The following is a description of a gene set: Human Gene Set: GOCC_PHAGOCYTIC_VESICLE_MEMBRANE The lipid bilayer surrounding a phagocytic vesicle. species: Homo sapiens, and this is the list of marker genes: MTMR4, RAC2, HLA-F, VAMP3, RAB9A, PIK3C3, TAP2, RAB11FIP1, RILP, SEC22B, ATP6V0D1, MCOLN1, STX4, RAB38, RAB9B, SLC9A9, ATP7A, RAB11B, RAB20, TAPBP, TLR2, RAB5A, HLA-H, DMBT1, B2M, HLA-C, LAMP1, DNM2, IRGM, RAB32, CORO1A, RAB10, HLA-B, INPP5B, TCIRG1 (T cell immune regulator 1, ATPase H+ transporting V0 subunit a3), HVCN1, ATP6V0E2, ATG12, RAB22A, RAB7A, ATP6V0A1, TAP1, PIP4P1, CALR, RAB34, ATP6V0C, RAB7B, PIK3R4, RAB31, RAB23, VAMP8, SNAP23, VAMP7, CLEC4E, ATG5, RAB8A (RAB8A, member RAS oncogene family), APPL2, TLR6, ATP6V0B, ANXA3, HLA-E, ATP6V0A4, TLR1, RAB43, RAB39A, CYBA, SYT7 (synaptotagmin 7), LAMP2, HLA-A, RAB8B, PIP4P2, ATP6V0E1, HLA-G (NCBI Gene Id 3135), OCRL, ATP6V0D2, SLC48A1, CYBB, PIKFYVE, ATP6V0A2, SLC15A2 (NCBI Gene Id 6565), SLC11A1, MPEG1